Given this list of marker genes DHTKD1, BTBD3, RHEBL1, ETV5, AK4, DESI2, GRK2, POLA2, SCML1 (Scm polycomb group protein like 1), POLR2D, ADAM19, CYTIP, GMNN, CKAP5, ELAVL1, EIF2AK4, PPP5C, CHEK2, USP44, NBN, ATP8B4, CCNE1, CCNE2, RAD18, RNASEH2A, NPLOC4, BEX5 (brain expressed X-linked 5), YES1, MRPL17, CXCL16, PFDN2, TTC28, AFG2A, RFWD3, MTHFD2, POLD3, HNF1B, CDC25A, SASS6, EAF2, POLR2H, ARHGAP19, ORC3, SEPHS1, GALK1, C18orf54, RRBP1, METTL22, ENDOD1, TBC1D22B, MAGED2, SECTM1, METTL5, CCDC150, FEN1, RAD23A (RAD23 homolog A, nucleotide excision repair protein), B3GALNT1, PRMT5 (NCBI Gene Id 415048), CYC1, XPO7, TUBGCP3, SINHCAF, MNAT1, FANCB, SNX10, TBCE, HSPA4L, CCNA1, MAP3K20, ODF2, GK, JAK2, CTPS1, ANXA3, NCAPD3, IRAK2, GRK5, HBEGF, PDE6D, MAP3K8, HLTF, ARHGAP11B, SMC1A, IFT122, COIL, NELFE, PFKFB4, CHAF1B, CBFB, NUDCD1, SRPK1, PRR3, EPS8, MPHOSPH9, GFPT1, EIF5B, NFIL3, XBP1, C1orf198, CCND3, SEMA3A, PIM1, ILF2, GNB4, EBP, SUV39H1, CBX5, PSMA5, IL1RAP, AP1M1, CCDC88A, CCND2, CHUK, ZBTB32, HSPA14, TXLNA, POLR2K, ECI1, SMC2, CCNF, GOT1, BSPRY, DEK, DHRS3, BRI3BP, AARS1, ADRM1 (ADRM1 26S proteasome ubiquitin receptor), BTG3, LAT2, DSCC1, TBRG4, C5orf34, NME7, MSRB1, TUBB4B, RAD54B, ASPHD2, CEP72, AP2B1, RFC2, FAH, DNA2, ING2, PA2G4, GNPAT, MID1, FAM162A, QSOX2, SMAP2, CA6, ITPRID2, HUS1B, PTPN3, BCL2L1, PDIA5, SOCS2, PHF7, GBE1 (NCBI Gene Id 2632), PLCG2, ZGRF1, CEP295, CPSF4, CTNNA1 (NCBI Gene Id 619480), PXYLP1, NEDD1, LRRC3, EIF4H, PRKCI, SRA1, MSH6, ACSS2, CDK6, HNRNPH3, NUP58, MAD2L1, AAAS, KIF2C, TOPBP1, NFKB1 (NCBI Gene Id 4790), SEC13, DNAJC12 (DnaJ heat shock protein family (Hsp40) member C12), TIPRL, H3-5, STAT3, ZEB1, FSCN1, INTS10, SLC15A4, ENO2, BMAL2 (NCBI Gene Id 56938), RIF1, NUF2, ARID3B, CDK5RAP2, REEP4, DNAJC21, LRR1, REXO5, EME1, SEC61A2, here is a description of the gene set: Human Gene Set: GSE32986_UNSTIM_VS_CURDLAN_HIGHDOSE_STIM_DC_UP A simultaneous engagement of different pathogen recognition receptors provides a tailor made adaptive immunity for an efficient defence against distinct pathogens. For example, cross talk of TLR and c-type lectin signalling effectively shapes distinct gene expression patterns by integrating the signals at the level of NF-κB. Here, we extend this principle to a strong synergism between the Dectin-1 agonist, curdlan, and an inflammatory growth factor, GM-CSF. Both together act in synergy in inducing a strong inflammatory signature which converts immature DCs to potent effector DCs. A variety of cytokines (IL-1β, IL-6, TNF-α, IL-2 and IL-12p70), costimulatory molecules (CD80, CD86, CD40 and CD70), chemokines (CxCl1, CxCl2, CxCl3, CCl12, CCl17) as well as receptors and molecules involved in fugal recognition and immunity such as Mincle, Dectin-1, Dectin-2 and Pentraxin 3 are strongly up-regulated in DC treated simultaneously with curdlan and GM-CSF. The synergistic effect of both stimuli resulted in strong IKBα phosphorylation, in its rapid degradation and in enhanced nuclear translocation of all NF-κB subunits. We further identified MAPK ERK, as one possible integration site of both signals, since its phosphorylation was clearly augmented when curdlan was co-applied with GM-CSF. Our data demonstrate that the immunomodulatory activity of curdlan requires an additional signal provided by GM-CSF to successfully initiate a robust β-glucan specific cytokine and chemokine response. The integration of both signals clearly prime and tailor a more effective innate and adaptive response against invading microbes and fungi. species: Homo sapiens from publication Min L, Isa SA, Fam WN, Sze SK, Beretta O, Mortellaro A, Ruedl C (PMID 22250091) Genes up-regulated in bone marrow-derived dendritic cells: unstimulated versus high dose of 1,3-beta-D-oligoglucan.